Given this list of marker genes CAPN13, ADAMTS4, CAPNS1, COL8A1, COL9A1, MMP9, CAPNS2, COL7A1, SPOCK3, TPSAB1, CD44, COL14A1, OPTC, COL3A1, BMP1, DCN, COL4A2, MMP14, MMP1, MMP17, CAPN7, ADAM8, CAPN9 (calpain 9), ADAMTS8, CAPN11 (calpain 11), FBN1, ADAM10 (ADAM metallopeptidase domain 10), ELANE, TLL2, CAPN6, LAMC2, FURIN, COL26A1, CAPN12, TIMP2, CAPN1 (calpain 1), PRSS1, LAMA5, ADAM9, MMP25, FBN2, MMP3, COL6A3, CTRB2, KLKB1, COL11A1, A2M, MMP15, COL6A1, PSEN1, ADAM15, SCUBE1, CAST, SCUBE3, MMP2, COL17A1, COL6A6, MMP8, COL4A4, ADAM17, PRSS2 (serine protease 2), COL2A1, COL13A1, COL5A3, CAPN5, BCAN, CAPN10, COL5A2, MMP12, CTSV, MMP24, SPP1, COL11A2, CAPN14, COL5A1, CTSD, MMP19, COL23A1, COL1A1, KLK7, FBN3, LAMA3, MMP16, CASP3, COL19A1, COL6A5, ACAN, HSPG2, TLL1, COL18A1, PLG, MMP11 (matrix metallopeptidase 11), MMP13, MMP10, COL4A1, CDH1, ADAMTS16, COL9A3, COL16A1, PHYKPL, LAMB3, ADAMTS9, CTSK, NID1, LAMC1, COL9A2, FN1 (fibronectin 1), CAPN2, COL15A1, COL4A5, CTSB, CTSL, CTSS, CTSG, TMPRSS6, CAPN8, LAMB1, HTRA1, COL4A6, COL8A2, ADAMTS5, KLK2, NCSTN (NCBI Gene Id 57297), COL25A1, BSG, CMA1, CAPN15, TIMP1, ADAMTS18, ELN, COL12A1, ADAMTS1, CAPN3, COL6A2, COL10A1 (NCBI Gene Id 93042), MMP20, COL4A3, MMP7 (NCBI Gene Id 4316), COL1A2, CTRB1, here is a description of the gene set: studied in species Homo sapiens Degradation of the extracellular matrix Human Gene Set: REACTOME_DEGRADATION_OF_THE_EXTRACELLULAR_MATRIX